Given this list of marker genes PRKCQ, PLCB1, KISS1R, PIK3CB, NFKB1, PDK1, MAP2K2, BMP15, MAPK3, MAP2K1, HSD3B1, KRAS, NRAS, PIK3CA, MMP9, MAPK1, PRKCB, KISS1, PRKCD, PRKCA, HRAS, ARRB2, PIK3CG, AKT2, PLCB4, AKT1, STAR, AMH, PIK3CD, CYP11A1, FSHR, PRKCE, PLCB2, PLCB3, PRKCG, RAF1, ARRB1, PRKCH, GDF9, here is a description of the gene set: species: Homo sapiens Human Gene Set: WP_KISSPEPTINKISSPEPTIN_RECEPTOR_SYSTEM_IN_THE_OVARY Kisspeptin/kisspeptin receptor system in the ovary